Given this list of marker genes PTPRS, RAB7B, GRAMD4, PPT1, LILRA4, here is a description of the gene set: Any process that stops, prevents, or reduces the frequency, rate, or extent of toll-like receptor 9 signaling pathway. species: Homo sapiens Human Gene Set: GOBP_NEGATIVE_REGULATION_OF_TOLL_LIKE_RECEPTOR_9_SIGNALING_PATHWAY